The following is a description of a gene set: from publication Ramilo O, Allman W, Chung W, Mejias A, Ardura M, Glaser C, Wittkowski KM, Piqueras B, Banchereau J, Palucka AK, Chaussabel D (PMID 17105821) studied in species Homo sapiens Genes up-regulated in comparison of peripheral blood mononuclear cells (PBMC) from healthy donors versus PBMC from patients with acute influenza infection. Human Gene Set: GSE6269_HEALTHY_VS_FLU_INF_PBMC_UP Each infectious agent represents a unique combination of pathogen-associated molecular patterns that interact with specific pattern-recognition receptors expressed on immune cells. Therefore, we surmised that the blood immune cells of individuals with different infections might bear discriminative transcriptional signatures. Gene expression profiles were obtained for 131 peripheral blood samples from pediatric patients with acute infections caused by influenza A virus, Gram-negative (Escherichia coli) or Gram-positive (Staphylococcus aureus and Streptococcus pneumoniae) bacteria. Thirty-five genes were identified that best discriminate patients with influenza A virus infection from patients with either E coli or S pneumoniae infection. These genes classified with 95% accuracy (35 of 37 samples) an independent set of patients with either influenza A, E coli, or S pneumoniae infection. A different signature discriminated patients with E coli versus S aureus infections with 85% accuracy (34 of 40). Furthermore, distinctive gene expression patterns were observed in patients presenting with respiratory infections of different etiologies. Thus, microarray analyses of patient peripheral blood leukocytes might assist in the differential diagnosis of infectious diseases., and this is the list of marker genes: PSEN2, TFR2, PRORP, TOMM7, VPS51, MAGED4B, QARS1 (NCBI Gene Id 5859), ASCC1 (NCBI Gene Id 51008), CXCR5, UBA52, TACR1, CFAP410, SORL1, KCTD7, NGB, PHF10, JADE1, SEPTIN7, PROC, ABCD4, SGPL1, LINC01963, PRKCB, RASGRP2, NFATC1, SEL1L3, PTDSS1, RPS28, GLS, PBXIP1, ZBTB40, EPHB1, NOP53, RPS3AP5, POLR2G (RNA polymerase II subunit G), PAOX, NDRG2, SRSF5, EIF3L, POU3F1, EML2 (NCBI Gene Id 24139), PRDM10 (NCBI Gene Id 56980, PR/SET domain 10), EIF3K, NSG1, FGF3, HIVEP2, IPO5, MGAT5, OGFOD2, PPOX, HNRNPA0, P4HTM, EEF1B2, ANAPC5, ARMCX6, EDEM1, EEF1G, MAN2B1, ELOVL5, SF3B3, CDC16, KLRB1, SARM1, SWAP70, DNPEP, AARSD1, BRD3OS, DDX27, FADS3, COX4I1, ZNF544 (NCBI Gene Id 27300), CCR6, LZTFL1, FABP1, RHOF, RPL4 (ribosomal protein L4), GNB5, RPL23, INTS11, HSPA1L, TMA7, RPL3, TNFRSF9, TBX2, EZH1, KDM1A, ATM, SUGP2, SUN2, ENO3, CSNK1G1, PRKCZ, EHD1, PRPF31, RPS12, DGCR8, EEF1A1P42, RPL29P5, DCAF8, KIF25, HLA-DQA1, BUB3 (NCBI Gene Id 9184), EIF2D, SAA1, CD1C, EIF3F, HMCES, BTF3, RPL22, UNC119B, RPL13A, TAOK3, RPL10A, KPNA6, ASXL3, RGP1, PWWP3A (NCBI Gene Id 84939), PLA2G6, SET, BAIAP3, FBL, RPL5, BTBD7, AKR7A2, NSUN5, KLC1, MCF2L-AS1, DRG2, UXT, MRNIP, DPH5, APOA1, C2orf68, SERPINF2, RPL36AP52, NEFM, SND1, NPFFR1, EIF3D, EIF3H, DAP3, RPS10, CPT1A, ABCB1, PAFAH2 (NCBI Gene Id 5051), EIF2B5, CERK, RLN1 (NCBI Gene Id 6013), CYP2R1 (NCBI Gene Id 79445), SERF1A, NDRG3, LUC7L, PDCD11, RABEP2, BTAF1, SNORA70, LRCH4, RPS14, ARL6IP4 (NCBI Gene Id 55913), RFTN1, HLA-DQB1, UBE2I, HMGN3, LILRA4, HUWE1, DELE1, FOXO1, CEP68, RPL17, UPF3A, NR3C1, RPL24, SGSM3, AFDN, IL16, RPS3A, RPL18A, RPL13